The following is a description of a gene set: species: Homo sapiens Human Gene Set: GOMF_SYNTAXIN_1_BINDING Binding to a syntaxin-1 SNAP receptor., and this is the list of marker genes: UNC13A, LRRK2, DAPK1, VAMP2, NSF, PRRT2, SNPH, VAMP3 (NCBI Gene Id 9341), SLC6A4, SYT1, UNC13B, STXBP1, CPLX1, CPLX2, SNAP25, STXBP2, STXBP5, STXBP3, UNC13C